The following is a description of a gene set: studied in species Homo sapiens Dendritic cells (DCs) process and present self and foreign antigens to induce tolerance or immunity. In vitro models suggest that induction of immunity is controlled by regulating the presentation of antigen, but little is known about how DCs control antigen presentation in vivo. To examine antigen processing and presentation in vivo we specifically targeted antigens to the two major subsets of DCs using chimeric monoclonal antibodies. Unlike CD8+ DCs that express the cell surface protein CD205, CD8- DCs, which are positive for the 33D1 antigen, are specialized for presentation on MHC class II. This difference in antigen processing is intrinsic to the DC subsets and associated with increased expression of proteins associated with MHC processing. from publication Dudziak D, Kamphorst AO, Heidkamp GF, Buchholz VR, Trumpfheller C, Yamazaki S, Cheong C, Liu K, Lee HW, Park CG, Steinman RM, Nussenzweig MC (PMID 17204652) Genes down-regulated in spleen dendritic cells from healthy mice: 33D1+ versus DEC205+ subpopulations. Human Gene Set: GSE6259_33D1_POS_VS_DEC205_POS_SPLENIC_DC_DN, and this is the list of marker genes: HMGCL, BTG2, TIPARP, LRIG2, CLCN4, MR1, KHNYN, RAB33A, ATP11A, RAB38, CD109, TACC1, MTSS1, H2AC6, SPRYD7, HJURP, YIPF6, SIPA1L2, SQOR, AJUBA, FCER1G, MOGAT2, EEPD1, SECTM1, IL1RN, CHN2 (NCBI Gene Id 644086), HAS3, ADAP1, STON1, AREG (amphiregulin), HEG1, LACC1, HSD17B10, FZD7, SLC45A4, CHRDL1, C10orf88, GTF2IRD1 (GTF2I repeat domain containing 1), MOB3A, ERGIC3, TMEM42, GUCY2C, WASF3, MAPK6, RPS3, ZBTB21, FUCA1, RNF144A, CCR7, DSCR4, SH3PXD2A, LRP5, LDLRAD4, KIF26A, MBTPS2, CEP19, IL7R, POLR3D, PHLDA3, TTC39C, CABP7 (calcium binding protein 7), DKK2, KRCC1, PEMT, ZBED1, ZSCAN5A (zinc finger and SCAN domain containing 5A), FUT7, ZMIZ1, STOM, RGS10, IGFBP4, GALNT2, SH3RF1, TNS3, CCNJL, MAF, EGR1, ZNF704, SLC43A3, TBC1D8, SOS1, RFTN1, RAB30, LPXN, RARS1, KATNB1, SETDB2, NOL9, SEPHS2, HIPK2, C11orf24, CDK15, PIGT, ACBD6, TUBB2A, GAD1, BMPR1A, FBXL12, CABLES1, MFAP1, CEBPA, SLC22A1, DDIT4, ELAC1, HERC2, CLN5 (CLN5 intracellular trafficking protein), SLC1A4, SEMA4A, TBC1D14, PPIF, ERLIN2 (NCBI Gene Id 140906), GPD2, ANKRD27, ZSCAN12, MAD2L2, PROM1, INTS9, CYP1B1, RAD51C, BAG3, UQCC4, TMEM51, RGL1, PTPRJ, PRSS23, RNFT2, NEK6, SLC17A5, CTSZ, AIFM1, PITPNA, SLC22A4, ARL3, CA8, RHOU, NGLY1, AHRR, NCOA3, EEIG1, SPATS2L, DOK2, SMIM3, FAM171A1, CYP1A1 (cytochrome P450 family 1 subfamily A member 1), PXMP4, KIT (NCBI Gene Id 5086), CMTM3, TSC22D3, EPB41L3, IRF2BPL, SYNJ2, KCNH5, ZNF264, ARL4C, ZFAS1, DDX1 (NCBI Gene Id 1653), EXTL2, GPR146, MAD1L1, GPX1 (glutathione peroxidase 1), ARRDC4, VDR, NORAD, GLCCI1, SPRY4, XYLT1, L3MBTL3, CD48, PACSIN2, IFITM3, GPR68, ALCAM, PDE4A, MFSD1, DAG1, AUTS2, PSMB2, RHOBTB3 (NCBI Gene Id 22836), SPNS2 (NCBI Gene Id 124976), INPP1, PTCH1, ADCY9, TUBB2B, PLIN2, GCSAML, DPY19L3, MRPL36 (NCBI Gene Id 64979), HS6ST1, MYDGF, NYNRIN, CXXC5, ABCG2, RSAD2, SARS1, SSH1, RFESD, HAPSTR1